Given this list of marker genes CSDE1, ZNF367, FAM136A, SRSF8, CACNA2D4, SYK, FES, UBTF, MYB, FAIM, NUCKS1, CKAP2, PHF10, IL23A (NCBI Gene Id 51561), HMGB1, TYMS, here is a description of the gene set: from publication Mariadason JM, Corner GA, Augenlicht LH (PMID 10969808) Cluster 4: genes down-regulated in SW260 cells (colon cancer) by sodium butyrate and sulindac. species: Homo sapiens The short-chain fatty acid butyrate, produced by microbial fermentation of dietary fiber in the large intestine, is a physiological regulator of major pathways of colonic epithelial cell maturation: cell cycle arrest, lineage-specific differentiation, and apoptosis. Microarray analysis of 8,063 sequences demonstrated a complex cascade of reprogramming of SW620 colonic epithelial cells upon treatment with butyrate characterized by the progressive recruitment of gene sets as a function of time. Comparison with the effects of trichostatin A, in conjunction with differences in the kinetics of alteration of histone acetylation induced by butyrate and trichostatin A, identified subsets of induced and repressed genes likely coordinately regulated by altered histone acetylation. The butyrate response was also compared in detail with that of sulindac, a nonsteroidal anti-inflammatory drug with significant chemopreventive activity for colon cancer, and curcumin, a component of mustard and curry structurally and functionally related to sulindac that also has chemopreventive activity. Although gene clusters were identified that showed similar responses to butyrate and sulindac, the data were characterized by the extensive differences in the effects of the two agents. This was striking for functional classes of genes involved in signaling pathways and in cell cycle progression, although butyrate and sulindac induce a similar G0-G1 arrest, elevation of beta-catenin-Tcf signaling, and apoptotic cascade. As regards cell cycle arrest, the underlying mechanism in response to butyrate was most similar to that of the Caco-2 cell line that had spontaneously undergone a G0-G1 arrest and least similar to the G2-M arrest stimulated by curcumin. Thus, high-throughput microarray analysis of gene expression profiles can be used to characterize and distinguish the mechanisms of response of colonic epithelial cells to physiological and pharmacological inducers of cell maturation. This has important implications for characterization of chemopreventive agents and recognition of potential toxicity and synergies. The data bases, gene clusters, and analyses are available at http:// sequence.aecom.yu.edu/genome/. Human Gene Set: MARIADASON_RESPONSE_TO_BUTYRATE_SULINDAC_4